Given this list of marker genes Prkar2b, Camkk1, Prkaca, Prkar1b, Calm1, Camkk2 (calcium/calmodulin-dependent protein kinase kinase 2, beta), Prkacb, Rps6ka6, Camk1, here is a description of the gene set: Reactome Pathway: Post NMDA receptor activation events This event has been computationally inferred from an event that has been demonstrated in another species.<p>The inference is based on the homology mapping from PANTHER. Briefly, reactions for which all involved PhysicalEntities (in input, output and catalyst) have a mapped orthologue/paralogue (for complexes at least 75% of components must have a mapping) are inferred to the other species. species: Mus musculus electronically inferred by orthology from the curated human pathway part of: Activation of NMDA receptors and postsynaptic events